The following is a description of a gene set: from publication Rashi-Elkeles S, Elkon R, Weizman N, Linhart C, Amariglio N, Sternberg G, Rechavi G, Barzilai A, Shamir R, Shiloh Y (PMID 16314843) The ATM protein kinase, functionally missing in patients with the human genetic disorder ataxia-telangiectasia, is a master regulator of the cellular network induced by DNA double-strand breaks. The ATM gene is also frequently mutated in sporadic cancers of lymphoid origin. Here, we applied a functional genomics approach that combined gene expression profiling and computational promoter analysis to obtain global dissection of the transcriptional response to ionizing radiation in murine lymphoid tissue. Cluster analysis revealed a prominent pattern characterizing dozens of genes whose response to irradiation was Atm-dependent. Computational analysis identified significant enrichment of the binding site signatures of NF-kappaB and p53 among promoters of these genes, pointing to the major role of these two transcription factors in mediating the Atm-dependent transcriptional response in the irradiated lymphoid tissue. Examination of the response showed that pro- and antiapoptotic signals were simultaneously induced, with the proapoptotic pathway mediated by p53 targets, and the prosurvival pathway by NF-kappaB targets. These findings further elucidate the molecular network induced by IR, point to novel putative NF-kappaB targets, and suggest a mechanistic model for cellular balancing between pro- and antiapoptotic signals induced by IR in lymphoid tissues, which has implications for cancer management. The emerging model suggests that restoring the p53-mediated apoptotic arm while blocking the NF-kappaB-mediated prosurvival arm could effectively increase the radiosensitivity of lymphoid tumors. Mouse Gene Set: RASHI_NFKB1_TARGETS studied in species Mus musculus Known and putative targets of NFKB1 identified among the ATM dependent, late responders to ionizing radiation., and this is the list of marker genes: Dusp6, Dusp16, Btg2, Mdm2 (transformed mouse 3T3 cell double minute 2), Ifngr2, Cxcl1, Nfkbia, Nfkbib (nuclear factor of kappa light polypeptide gene enhancer in B cells inhibitor, beta), Relb, Cxcl2, Map3k8, Irf1, Tnip1, 2410002F23Rik, Csf1, Nfkb2, Birc3 (NCBI Gene Id 11796), Tnfaip3, Lcn2